Given this list of marker genes CDKN2B, KCNQ1OT1, CYP11B1, CHEK2, CLCN2, IDH1, IDH2, CDKN2A, SCN4A, CDKN1A, ZNRF3, CYP11B2, CACNA1S, TERT, CDKN2C, TP53, KCNQ1, CTNNB1, IGF2, MEN1, KCNE3, PTEN, CDKN1C, CDKN1B, PRKAR1A, APC, MDM2, here is a description of the gene set: studied in species Homo sapiens Neoplasm of the adrenal cortex The presence of a neoplasm of the adrenal cortex. Human Gene Set: HP_NEOPLASM_OF_THE_ADRENAL_CORTEX